Given this list of marker genes FAH, IL4I1, PAH, GSTZ1, QDPR, HGD, TAT, HPD, here is a description of the gene set: The chemical reactions and pathways involving L-phenylalanine, the L-enantiomer of 2-amino-3-phenylpropanoic acid, i.e. (2S)-2-amino-3-phenylpropanoic acid. species: Homo sapiens Human Gene Set: GOBP_L_PHENYLALANINE_METABOLIC_PROCESS